The following is a description of a gene set: species: Homo sapiens Human Gene Set: GSE17580_TREG_VS_TEFF_DN Genes down-regulated in comparison of regulatory T cell (Treg) from uninfected mice versus T effector cells from uninfected mice. from publication Layland LE, Mages J, Loddenkemper C, Hoerauf A, Wagner H, Lang R, da Costa CU (PMID 20007528) Although several markers have been associated with the characterization of regulatory T cells (Treg) and their function, no studies have investigated the dynamics of their phenotype during infection. Since the necessity of Treg to control immunopathology has been demonstrated, we used the chronic helminth infection model S. mansoni to address the impact on the Treg gene repertoire. Before gene expression profiling we first chose to study the localization and antigen-specific suppressive nature of classically defined Treg during infection. Presence of Foxp3+ cells were found especially in the periphery of granulomas and isolated CD4+CD25hiFoxp3+ Treg from infected mice blocked IFN-gamma and IL-10 cytokine secretion from infected CD4+CD25- effector T cells (Teff). Furthermore the gene expression patterns of Treg and Teff showed that in total genes were significantly regulated during chronic schistosomiasis. Upon k-means clustering we identified genes exclusively regulated in all four populations including Foxp3, CD103, GITR, OX40 and CTLA-4: classical Treg markers. During infection however, several non-classical genes were up-regulated solely within the Treg population such as Slpi, Gzmb, Mt1, Fabp5, Nfil3, Socs2, Gpr177 and Klrg1. Using RT-PCR we confirmed aspects of the microarray data and in addition showed that the expression profile of Treg from S. mansoni-infected mice is simultaneously unique and comparative with Treg derived from other infections, and this is the list of marker genes: GOLGA3, RAP2A, CTSD, NUP50, DOCK7, NPC1, PEA15, RASGRP2, BBS9, ANKRD13A, LAMTOR1, SQSTM1, VSIR, VPS35L, BTC, CLEC10A, OTUB2, CHST1, SLC37A1, ARID2, HEXD, SIT1, MLST8, HLCS, ZFP14, HPCAL1, HVCN1, ACTN1, COX6A2, FCGRT, PNPLA7, PTPRK (NCBI Gene Id 5796), DENND2D, ARL4C (NCBI Gene Id 10123), MANBA, ATG2B, RPS3, ANO10, DAP, GAB3, INTS7, IDH2, ABHD15, MFN2, SPSB1, RNF111, CD47, HEXIM1, TOLLIP, SURF6, AXIN1, RAPGEF4, FASLG, PDLIM1, FAM234B, NUDT3, ME2, THY1, LRRN1, TXK, RBM15B, EPAS1, SHISA2, TP53I13, NPHS2, IFITM10, UHMK1, PLEKHA5, THRAP3, RANBP10, CHD7, DCAF1, PRR5, PIK3CG, CDKN2D, LONP2, LBP, TANC1, ATG4D, MRPS5, APP, DOCK5, GUCD1, CXCR6, DYM, CPNE1, UTP4, SPTBN1, TRMT44, RAB8A, COG8, ARL2, TMEM47, ZNF418, ANAPC5, SLC22A4, TBXA2R, CDCA4, RALB, SETD3, ATP6V1A (NCBI Gene Id 523), CREB3L4, ST8SIA1, ATP6V0B, PLD3, STARD7, TEX264, RHBDL3, MAP4, STK38, CHURC1, GRAP2, BRDT, SCML4, ELP3, CYB5R4, ATF5, NUP153, RPL14, LAIR1, ENC1, SLA2, TCF7, STK17B, CDH1, WASF2, SH3BGRL3, FZD5, MYO10, ATP11B, PEX5, CD34, ANKMY2, ABHD3, SMAGP (NCBI Gene Id 57228), EIF5B, SLC39A7, NFE2L2, HMGCS1, TAGLN2, SPEF1, HOXD12, LYST, SLC12A7, ETV3 (NCBI Gene Id 2117), TSC22D1, EVI2A, TXNDC11, DOP1B, ACP5, YWHAG, SMPD1, ACVR1B (activin A receptor type 1B), CSDE1, PI4KA, AKR1B15, RMND5B, ADGRG3, PRSS16, APPL2, MEIS1, CCDC106 (NCBI Gene Id 29903), TIFA, EMB, SLC30A4, BLTP3B, TBC1D1, ACVRL1, IBTK, ID2, ATP1B1, KBTBD2, ZDHHC5, HSD11B1, UFSP1, ACTN2, HEATR1, GSN, PRKD3, RNF38, TNKS2, CDC42SE1, ZNF436, FBXL14, CLPB, TCTA, CHP1, GID4, NAP1L4, S1PR4, SCYL1, SYNE2, NXN, ZNF521, ANGPTL7, APOBR, CSNK1E, LEF1 (lymphoid enhancer binding factor 1), PNPO, MYCT1